Given this list of marker genes PARP14, HIVEP2, APOBEC3F (NCBI Gene Id 29762), CAMK2D, SERPINF1, FBXO6, PLAAT4, NEXN, C2, APOL6 (apolipoprotein L6), PRRT2, GBP1, OLIG1, IFIT5, RASL11A, CTSL, IFI44L, JAK3, APOL2, PARP9, MIR21, SMTNL1, APOL3, LMTK2, PSME2P2, XRN1, IFI35, TAP2, PROS1 (NCBI Gene Id 5627), IFIT1, IDO1, CARINH, SEMA6B, TRPC2, IL12RB1, CFB, CDCP1, KRT80, RSAD2, EPSTI1, SLAMF7 (NCBI Gene Id 57823), STAMBPL1, CARD17P, STOM, P2RY12, ADAMTS10, SLC39A8, ADAMTSL4-AS1, GBP2, CLEC17A, CIMAP1B, STX11, TIFA, IL15RA, ANKRD22, LMNB1, CXCL10, PCED1B, IGHEP2, PRSS21, SERPING1, HAPLN3, SOX12, DES, PPARGC1A, PSME2, ZBP1, GVINP1, IL31RA, ASAP2, RNU7-40P, CYP4F22, FAM89A, PLAC8 (placenta associated 8), CD40, VPS9D1, HSPA6, GAS6, VAMP5, PRDM11, CUL1, ADGRV1, ORC6, H2BC18, ADM, SLAMF8, DTX3L, SEPTIN4, PITPNM2, SP140, GFRA2, TGM2, LAP3, IL27, CDK5R1, SECTM1, CD69, HP, VSIG2, MRPS18AP1, MTND6P5, PSTPIP2, CMPK2, APOBEC3B, CD1E, OAS3, C21orf58, DYSF, LGALS3BP, DOC2A, FRMD3, SDC3, IFIT3 (NCBI Gene Id 8376), KLHDC7B, ALOX15B, SLC6A12, STAT1, KREMEN1, LIMK2, FCGR1BP, TNFAIP6, CASP7, CASP5, GBP5, FANCL, MUC1, BCL2A1, NAMPT, PLEKHG6, GBP4, ADCY3, PRR5L, AQP9, ADARB1, METAP1D, CXCR2P1, ARID5B, PIM1, TNFSF10, GCH1, DUSP5, ETV7, IFITM3, KIFC3, CD9, IFIT2, FCGR1A, OASL, MYOF, OPTN, PML, TYMP (NCBI Gene Id 4334), GPR84, SAMD9L, OAS2, EXOC3L1, ATP1B2, SAMD4A, ISG20, NLRC5, XAF1, ANXA9, XKR8, TCN2, RTP4, CALHM6, RHOBTB3, FCRL6, SOCS3, IRF7, LMNA, CLU, ENPP2, FCGR2B, GBP1P1, CDHR5, CCL2, HIC1, KCNJ15, ACSL1, GPC2, MT2A (NCBI Gene Id 4502), RAB20, BMAL2, UBE2L6, APOL1, BRCA2 (BRCA2 DNA repair associated), AANAT, CD7, MAP3K7CL, AIM2, IRF1 (NCBI Gene Id 96501), PSMB9, FPR2, CD274, DDX60, APOBEC3A, NR1D1, TRANK1 (NCBI Gene Id 9881), FBXO24, WARS1, BATF2, IFI44, SAMD9, IFITM1, SCO2, HLA-DOB, FILIP1L, ISG15, AMIGO2, FAM225A, ZNF702P, PFKFB3 (6-phosphofructo-2-kinase/fructose-2,6-biphosphatase 3), IGF2BP3, SEPTIN14 (septin 14), CETP, RNF213, FFAR2, STAT2, AVPI1, GNG10, HERC5, APOL4, TAP1, PRICKLE1 (NCBI Gene Id 144165), FAM20A, CD38, FAM157A, RIMKLB, OXR1, GBP3, here is a description of the gene set: Genes up-regulated in monocyte 1d vs 0d in adults (18-49) after exposure to inactivated monovalent influenza A/Indonesia/05/2005 H5N1 split-virus vaccine, time point 1D, administered i.m. from publication Howard LM, Hoek KL, Goll JB, Samir P, Galassie A, Allos TM, Niu X, Gordy LE, Creech CB, Prasad N, Jensen TL, Hill H, Levy SE, Joyce S, Link AJ, Edwards KM (PMID 28099485) Human Gene Set: HOWARD_MONOCYTE_INACT_MONOV_INFLUENZA_A_INDONESIA_05_2005_H5N1_AGE_18_49YO_1DY_UP BACKGROUND: Vaccine development for influenza A/H5N1 is an important public health priority, but H5N1 vaccines are less immunogenic than seasonal influenza vaccines. Adjuvant System 03 (AS03) markedly enhances immune responses to H5N1 vaccine antigens, but the underlying molecular mechanisms are incompletely understood. OBJECTIVE: We compared the safety (primary endpoint), immunogenicity (secondary), gene expression (tertiary) and cytokine responses (exploratory) between AS03-adjuvanted and unadjuvanted inactivated split-virus H5N1 influenza vaccines. In a double-blinded clinical trial, we randomized twenty adults aged 18-49 to receive two doses of either AS03-adjuvanted (n = 10) or unadjuvanted (n = 10) H5N1 vaccine 28 days apart. We used a systems biology approach to characterize and correlate changes in serum cytokines, antibody titers, and gene expression levels in six immune cell types at 1, 3, 7, and 28 days after the first vaccination. RESULTS: Both vaccines were well-tolerated. Nine of 10 subjects in the adjuvanted group and 0/10 in the unadjuvanted group exhibited seroprotection (hemagglutination inhibition antibody titer > 1:40) at day 56. Within 24 hours of AS03-adjuvanted vaccination, increased serum levels of IL-6 and IP-10 were noted. Interferon signaling and antigen processing and presentation-related gene responses were induced in dendritic cells, monocytes, and neutrophils. Upregulation of MHC class II antigen presentation-related genes was seen in neutrophils. Three days after AS03-adjuvanted vaccine, upregulation of genes involved in cell cycle and division was detected in NK cells and correlated with serum levels of IP-10. Early upregulation of interferon signaling-related genes was also found to predict seroprotection 56 days after first vaccination. CONCLUSIONS: Using this cell-based systems approach, novel mechanisms of action for AS03-adjuvanted pandemic influenza vaccination were observed. TRIAL: ClinicalTrials.gov NCT01573312. species: Homo sapiens